The following is a description of a gene set: The clustering process in which postsynaptic density protein 95 (PSD-95) molecules are localized to distinct domains in the cell membrane. PSD-95 is mostly located in the post synaptic density of neurons, and is involved in anchoring synaptic proteins. Human Gene Set: GOBP_POSTSYNAPTIC_DENSITY_PROTEIN_95_CLUSTERING species: Homo sapiens, and this is the list of marker genes: SLC30A1, RELN, CRIPT, LRRC4, ZMYND8, NLGN1, NRXN1, NLGN2, CDH2, NRXN2